The following is a description of a gene set: part of: Clathrin-mediated endocytosis Reactome Pathway: Cargo recognition for clathrin-mediated endocytosis Recruitment of plasma membrane-localized cargo into clathrin-coated endocytic vesicles is mediated by interaction with a variety of clathrin-interacting proteins collectively called CLASPs (clathrin-associated sorting proteins). CLASP proteins, which may be monomeric or tetrameric, are recruited to the plasma membrane through interaction with phosphoinsitides and recognize linear or conformational sequences or post-translational modifications in the cytoplasmic tails of the cargo protein. Through bivalent interactions with clathrin and/or other CLASP proteins, they bridge the recruitment of the cargo to the emerging clathrin coated pit. The tetrameric AP-2 complex, first identified in early studies of clathrin-mediated endocytosis, was at one time thought to be the primary CLASP protein involved in cargo recognition at the plasma membrane, and indeed plays a key role in the endocytosis of cargo carrying dileucine- or tyrosine-based motifs. <br><br>A number of studies have been performed to test whether AP-2 is essential for all forms of clathrin-mediated endocytosis. Although depletion of AP-2 differentially affects the endocytosis of different cargo, extensive depletion of AP-2 through RNAi reduces clathrin-coated pit formation by 80-90%, and the CCPs that do form still contain AP-2, highlighting the critcical role of this complex in CME.<br><br><br>In addition to AP-2, a wide range of other CLASPs including proteins of the beta-arrestin, stonin and epsin families, engage sorting motifs in other cargo and interact either with clathrin, AP-2 or each other to facilitate assembly of a clathin-coated pit. species: Homo sapiens, and this is the list of marker genes: GRB2, SNAP91, APOB (apolipoprotein B), FCHO2, AP2A2, EPS15, CFTR, IGF2R, AVP, UBQLN2, VAMP7, EPN2, CD4, SYT11, CHRM2, COPS2 (COP9 signalosome subunit 2), SYT2, COPS5, SCARB2, LDLRAP1, STAM, HBEGF, FZD4, COPS3, ITSN2 (NCBI Gene Id 6454), EPN1, AP2A1, VAMP3, REPS2, EREG, REPS1, CD3D, EPGN, SH3GL2 (NCBI Gene Id 6456), NECAP1, GRK3, SGIP1, VAMP2, M6PR, AGTR1, NECAP2, EPS15L1, VAMP8, FCHO1, CLTCL1, CD3G, IL7R, STON2, STON1, SYT8, AGFG1, WNT5A, TOR1B (NCBI Gene Id 84822), ARRB2, TFRC, SYT9 (synaptotagmin 9), GPS1, SH3GL1, EGF, COPS4, UBQLN1, COPS7A, EGFR, COPS7B, SLC2A8, DAB2, ARRB1, AREG, TGFA, TF, SH3KBP1, COPS6, TOR1A, CBL, AVPR2, COPS8, ADRB2, TACR1, RPS27A (ribosomal protein S27a), LRP2, SLC18A3, GRK2, SYT1, DVL2, CLTA, VAMP4, STAM2, ITSN1, AP2M1, AP2B1, CLTB, SH3GL3, BTC, HGS, NEDD8, CLTC, UBC, AP2S1, KIAA0319, AAK1, PICALM, LDLR, UBA52, UBB, TGOLN2